Given this list of marker genes SLC9A6, SIN3A, HNRNPH2, KANSL1, SATB2, NALCN, UNC80 (NCBI Gene Id 84540), here is a description of the gene set: An unusually happy demeanor over time, which can also be observed during inappropriate situations that should, for example, cause distress, fear, or anger. Conspicuously happy disposition Human Gene Set: HP_CONSPICUOUSLY_HAPPY_DISPOSITION species: Homo sapiens